Given this list of marker genes Gip, Crh, Igf1, Hcrt, Pdyn, Pcsk2, Prtn3, Vps13a, Ins1, Ins2, Serpini1, Penk, Gcg, Pcsk1, Adcyap1, Spaca7, Apob, Lcn2, Egfr, Dbh, Ghrl, Prss57, Grp, Fasl, Ada, Zp3r, Spata31 (spermatogenesis associated 31), here is a description of the gene set: The volume enclosed by the membrane or protein that forms a vesicle. Mouse Gene Set: GOCC_VESICLE_LUMEN species: Mus musculus